Given this list of marker genes AKR1D1, ABCB11 (ATP binding cassette subfamily B member 11), HSD17B4 (hydroxysteroid 17-beta dehydrogenase 4), CYP8B1, CYP27A1, AKR1C2, SLC27A2, CYP7B1, AKR1C3, NR1H4 (NCBI Gene Id 9971), HSD3B7, AMACR, NCOA1, RXRA, BAAT, SLC27A5, AKR1C1, CYP7A1, AKR1C4, SCP2, ACOX2, NCOA2, ACOT8, here is a description of the gene set: Human Gene Set: REACTOME_SYNTHESIS_OF_BILE_ACIDS_AND_BILE_SALTS_VIA_7ALPHA_HYDROXYCHOLESTEROL Synthesis of bile acids and bile salts via 7alpha-hydroxycholesterol studied in species Homo sapiens